Given this list of marker genes STEAP2, SLC31A2, ATP7B, SLC31A1, ATP7A, STEAP3, STEAP4, here is a description of the gene set: The directed movement of copper ions into a cell or organelle. Human Gene Set: GOBP_COPPER_ION_IMPORT studied in species Homo sapiens